The following is a description of a gene set: Human Gene Set: chr3p14 species: Homo sapiens, and this is the list of marker genes: DNASE1L3, WDR53P1, SNRPB2P1, LINC00698, PSMD6-AS2, MAGI1, ACOX2, ARHGEF3-AS1, LINC00994, RNU6-108P (RNA, U6 small nuclear 108, pseudogene), ENSG00000288039, CFAP20DC-AS1, WNT5A-AS1, ADAMTS9, THOC7, PRICKLE2-DT, DENND6A (NCBI Gene Id 201627), NDUFB4P1, TAFA4, PSMC1P1, CDHR18P, APPL1, FHIT, ENSG00000286967, RPS15P5, RNU6ATAC26P, ILF2P1, EOGT-DT, FLNB, CACNA2D3-AS1, RNU6-483P, RN7SKP45, FAM3D, HESX1, RPS8P5, RNU6-739P, RPLP0P8, ENSG00000304774, PPIAP16, TMED2P1, PSMD6, RNA5SP135, RNU6-1181P, TAFA1, PDE12, SCAANT1, LMOD3, RPL27P9, ERC2-IT1, ARHGEF3, PRICKLE2-AS1, RNU6-787P (RNA, U6 small nuclear 787, pseudogene), SNTN, TCEAL8P1, PPIAP70, RPL21P41, RNU6-139P, LCORLP1, FLNB-AS1, RNU2-10P, LINC02017, ENSG00000212211, RN7SL863P, KCTD6, RBM43P1, PSMD6-AS1, FAM3D-AS1, ADAMTS9-AS1 (ADAMTS9 antisense RNA 1), ABHD6, ARF4, SYNPR, ENSG00000296009, LINC02030, SPATA12, ID2B, SUCLG2-DT, DENND6A-DT (NCBI Gene Id 101929159), SLC25A26, ENSG00000295559, RPP14, RN7SL482P, H1-8P1, ESRG, ASB14, ARL6IP5, SYNPR-AS1, RPL19P2, PXK, RNA5SP134, FRMD4B, RPL14P2, MAGI1-AS1, MAGI1-IT1, RPL10AP6, SUCLG2, PTPRG-AS1, PDHA1P1, LINC02040, PRICKLE2-AS2 (NCBI Gene Id 100874242), PRICKLE2, KRT8P35 (keratin 8 pseudogene 35), DNAH12, ENSG00000242775, ENSG00000200222, HTD2, RPS10P10, ENSG00000294089 (NCBI Gene Id 105377106), PRICKLE2-AS3, PPIAP71, CFAP20DC-DT, FAM107A, MIR3136, CADPS, MTERF1P1, LRTM1, CCDC66, PDHB, PRDX3P4, UBL5P3 (ubiquitin like 5 pseudogene 3), KBTBD8, MIR4272, MIR3938, EOGT, RPL17P17, COPS8P2, THOC7-AS1, TASOR, PTPRG, ADAMTS9-AS2 (ADAMTS9 antisense RNA 2), C3orf49, TMF1, RNF7P1, MIR548BB, LRIG1, WNT5A, ERC2, CFAP20DC, UBA3, CEP15, ATXN7, SLMAP, IL17RD, RNA5SP133, FEZF2